Given this list of marker genes TEAD3, PRKAA2, CYP26B1, TATDN3, APOBR, FBXW7, CHD9, BICD2, DDHD2, NMT1, KCNB1, GOLGA8A, GOLGA6L10, AFF1, CCNT2, NABP2, ZNF516, RRAGC, FCF1, PLA2G4E, GOLGA6C, SNRPF, MTCL2, ROBO4, RCN1, SYNCRIP, FBLN1, FGF11, GPC5, GOLGA6D, SNX18, LARS2, LRFN5, ALPK3 (NCBI Gene Id 57538), CNBP, KIF6 (kinesin family member 6), KIAA0040, TNS3, CSTF2, CRISPLD1, EPGN, LUC7L3 (NCBI Gene Id 51747), HNF4A, STAM, PHF20, MAK16, GSPT1, ZNF280B, PPP3CB, CA12, SMCO3, PPTC7, GPR34, IRX2, PAPPA, TWIST1, PEDS1, PPME1, RORA, CHD2, ATP2B1, GOLGA6A, RTL5, ARHGAP26, PTPN12, KCNIP4, CPOX, IAH1, ANKUB1, SNCAIP, SFPQ, QKI, SLC4A8, MAP4K5, LMNTD1, RAB11FIP1, SDC2, RALA, DCX, ARID2, GOLGA6B, LRRC3B, PHF20L1, UPB1, AGXT2, ZSCAN29, PDE5A, KBTBD8, STAG2, MRPS21, here is a description of the gene set: Human Gene Set: MIR5693 studied in species Homo sapiens Genes predicted to be targets of miRBase v22 microRNA hsa-miR-5693 in miRDB v6.0 with MirTarget v4 prediction scores > 80 (high confidence targets). from publication Chen Y, Wang X (PMID 31504780)